Given this list of marker genes EXOSC6, EXOSC10, EXOSC2, EXOSC7, EXOSC1, EXOSC9, EXOSC3, EXOSC4, EXOSC5, EXOSC8, here is a description of the gene set: Human Gene Set: GOCC_NUCLEOLAR_EXOSOME_RNASE_COMPLEX studied in species Homo sapiens A ribonuclease complex that has 3-prime to 5-prime distributive hydrolytic exoribonuclease activity and in some taxa (e.g. yeast) endoribonuclease activity, producing 5-prime-phosphomonoesters. Participates in a multitude of cellular RNA processing and degradation events preventing nuclear export and/or translation of aberrant RNAs. Restricted to processing linear and circular single-stranded RNAs (ssRNA) only. RNAs with complex secondary structures may have to be unwound or pre-processed by co-factors prior to entering the complex, esp if the 3-prime end is structured.